Given this list of marker genes Smpd2, Enpp7, Smpdl3b, Abca8a, Prkcd, Samd8, Smpdl3a, Ormdl1 (NCBI Gene Id 252836), Abca2, Smpd3, Vapa, Smpd5, Smpd4, Sgms2, Ormdl3, Abca8b, Sgms1, Smpd1, Sptlc2, Pemt, Sptlc1, Osbp, here is a description of the gene set: The chemical reactions and pathways involving sphingomyelin, N-acyl-4-sphingenyl-1-O-phosphorylcholine, any of a class of phospholipids in which the amino group of sphingosine is in amide linkage with one of several fatty acids, while the terminal hydroxyl group of sphingosine is esterified to phosphorylcholine. studied in species Mus musculus Mouse Gene Set: GOBP_SPHINGOMYELIN_METABOLIC_PROCESS